The following is a description of a gene set: from publication Cao J, O'Day DR, Pliner HA, Kingsley PD, Deng M, Daza RM, Zager MA, Aldinger KA, Blecher-Gonen R, Zhang F, Spielmann M, Palis J, Doherty D, Steemers FJ, Glass IA, Trapnell C, Shendure J (PMID 33184181) The gene expression program underlying the specification of human cell types is of fundamental interest. The study authors generated human cell atlases of gene expression and chromatin accessibility in fetal tissues. For gene expression, the study authors applied three-level combinatorial indexing to >110 samples representing 15 organs, ultimately profiling ~4 million single cells. The study authors leveraged the literature and other atlases to identify and annotate hundreds of cell types and subtypes, both within and across tissues. Our analyses focused on organ-specific specializations of broadly distributed cell types (such as blood, endothelial, and epithelial), sites of fetal erythropoiesis (which notably included the adrenal gland), and integration with mouse developmental atlases (such as conserved specification of blood cells). These data represent a rich resource for the exploration of in vivo human gene expression in diverse tissues and cell types. Human Gene Set: DESCARTES_FETAL_INTESTINE_MYELOID_CELLS Marker genes curated from the annotated cluster as represented in the Descartes Human Gene Expression During Development database. species: Homo sapiens, and this is the list of marker genes: LILRA2, TLR1, RAB20, LINC01478, RNASE6, LILRB2, CSF3R, FLT3, SLC39A13-AS1, IL10RA, FMN1, LILRB1, GAPT, CD300LB (NCBI Gene Id 124599), CPVL, PTPRN2-AS1, OSCAR, HLA-DPA1, MS4A6A, KCNG2, CD4, CD74, MEFV, NAMPT, SLC24A4, MNDA, RPL32P1, LINC02953 (NCBI Gene Id 102724265), CD86, CD83, WFDC21P, NCF2, LINC01678, LILRA6, SIGLEC12, VSIG4, ZMYND15, C1orf162, CYBB, HLA-DQA1, SIGLEC1, P2RY12, ADAP2 (ArfGAP with dual PH domains 2), SCIMP, BID, SLC1A3-AS1, C1QC, FOLR2, FCER1G, ITGAX, LY86, IL6R, CD300LF, BCL2A1 (NCBI Gene Id 597), F13A1, HLA-DQA2, RETN, ADGRE2, TASL, TBXAS1, RUFY4, IL31RA, GPR183, CLEC7A, CD101, RGS18, HLA-DRB6, RYR1, NLRP3, ZNF385A, SIRPB2, RN7SL368P, PLD4, STX11, IFI30, FCN1, CCR1, IDO1, TNNI2, MAN2B1, FGD2 (NCBI Gene Id 221472), SLC31A2, MMP9, NLRC4 (NCBI Gene Id 58484), CMKLR1, HLA-DMA, CACNB4, DAPP1, TNFRSF13C, NUAK2, SDS, SIGLEC5, CLEC9A, MS4A14, C5AR2, VMO1, CIITA, NCKAP5-AS2, ITPR2, CX3CR1, MPEG1, NCF1, LINC00996, ENSG00000227531, TYMP, IL1R2 (NCBI Gene Id 7850), TLR6, THEMIS2, CXCL8, ENSG00000254288, C1QB, RASGRP4, CD1D, MAFB, SMIM35, MCOLN2, ADGRE1, MILR1, CD274, EBI3, HLA-DQB1, CD300C, AIF1, FCGR3A, ABCA1, HLA-DOA, CCR2, HLA-DRB5, MS4A4A, DNASE1L3, FCER2, TNFAIP8L2, GPR141, CLEC4C, RN7SL297P, C5AR1, LINC02513, IL10, P2RY13, CFP, STAB1, CD33, CSF2RA, TLR10, IRF8, CSF1R, IGSF6, TYROBP, MARCHF1, IL1B (interleukin 1 beta), HRH1, PTAFR (platelet activating factor receptor), CD209, FPR3, CR1 (NCBI Gene Id 1378), HRH2 (NCBI Gene Id 3274), CCDC170, WDFY4, SECTM1, CD207, ZDHHC19, HLA-DMB, HLA-DRB1, LINC01299, SIGLEC10, CD14, CCDC26, CXCL9, MS4A7, RILPL2, RN7SL138P, SCN4B, CD1C, CD180, CYRIA, PLEK, PTCRA, ENSG00000231873, HLA-DRB9, NCF4, CLEC10A, TREM1, CD163, C3AR1, HLA-DPB1, RNASET2, CCL22, ACP3, GPR34, LILRB3, TLR7, FCGR1A, CD163L1, DCANP1, NAPSB, HPGDS, C1QA, SIGLEC14, CST3, CXCL10, HCK, FCGR2A, ENSG00000258168, LINC01248, CD200R1, TIFAB (NCBI Gene Id 497189), LGMN, TLR8, LILRA1, NME8, SAMHD1, PDCD1LG2, CXCR2P1, MS4A4E, SPI1, FPR1, FGL2, AOAH, KYNU, CD300E, MERTK, CTSS, SLAMF7, LILRB5 (NCBI Gene Id 10990), LILRB4, LILRA5, TCHH, ADGRE3, HLA-DRA, LYZ, HCAR3, CLEC4F, LINC01645